Given this list of marker genes Hnf4g, Cacna1a, Ndn, Meis3, Tfcp2l1, Mef2c, Sfrp4, Hoxa4, Nr1i3, Eya3, Zfp93, Hic1, Pias3, Sowahc, Hoxa6, Esrrb, Nfatc2, Aire, Pdx1, Lcor, Evx2, Sox6, Crx, Mycl, Tcf21, here is a description of the gene set: Mouse Gene Set: RIZ_ERYTHROID_DIFFERENTIATION_APOBEC2 studied in species Mus musculus from publication Riz I, Akimov SS, Eaker SS, Baxter KK, Lee HJ, Mariño-Ramírez L, Landsman D, Hawley TS, Hawley RG (PMID 17213805) Selected genes whose expression profile follows that of APOBEC2 in the TLX1 Tet On iEBHX15-4 cells (pro-erythroblasts). Aberrant expression of the human homeobox-containing proto-oncogene TLX1/HOX11 inhibits hematopoietic differentiation programs in a number of murine model systems. Here, we report the establishment of a murine erythroid progenitor cell line, iEBHX1S-4, developmentally arrested by regulatable TLX1 expression. Extinction of TLX1 expression released the iEBHX1S-4 differentiation block, allowing erythropoietin-dependent acquisition of erythroid markers and hemoglobin synthesis. Coordinated activation of erythroid transcriptional networks integrated by the acetyltransferase co-activator CREB-binding protein (CBP) was suggested by bioinformatic analysis of the upstream regulatory regions of several conditionally induced iEBHX1S-4 gene sets. In accord with this notion, CBP-associated acetylation of GATA-1, an essential regulator of erythroid differentiation, increased concomitantly with TLX1 downregulation. Coimmunoprecipitation experiments and glutathione-S-transferase pull-down assays revealed that TLX1 directly binds to CBP, and confocal laser microscopy demonstrated that the two proteins partially colocalize at intranuclear sites in iEBHX1S-4 cells. Notably, the distribution of CBP in conditionally blocked iEBHX1S-4 cells partially overlapped with chromatin marked by a repressive histone methylation pattern, and downregulation of TLX1 coincided with exit of CBP from these heterochromatic regions. Thus, we propose that TLX1-mediated differentiation arrest may be achieved in part through a mechanism that involves redirection of CBP and/or its sequestration in repressive chromatin domains.